The following is a description of a gene set: Conditional macrophage-specific PPARg knockout mice were generated on C57Bl/6 background by breeding PPARg fl/- (one allele is floxed, the other is null) and lysozyme Cre transgenic mice. PPARg and IL-4 signaling was analyzed on bone marrow-derived macrophages. Bone marrow of 3 mice per group was isolated and differentiated to macrophages with M-CSF (20 ng/ml). 20 ng/ml IL-4 was used to induce alternative macrophage activation and 1 uM Rosiglitazone (RSG) was used to activate PPARg. From each mouse 4 samples were generated: 1. M-CSF, 2. M-CSF+RSG, 3. IL-4 and 4. IL-4+RSG. All compounds were added throughout the whole differentiation process, and fresh media was added every other day. Control cells were treated with vehicle (DMSO:ethanol). After 10 days, RNA was isolated and gene expression profiles were analyzed using Mouse Genome 430 2.0 microarrays from Affymetrix. Human Gene Set: GSE25123_WT_VS_PPARG_KO_MACROPHAGE_IL4_STIM_DN from publication Szanto A, Balint BL, Nagy ZS, Barta E, Dezso B, Pap A, Szeles L, Poliska S, Oros M, Evans RM, Barak Y, Schwabe J, Nagy L (PMID 21093321) Genes down-regulated in bone marrow-derived macrophages treated with IL4: wildtype versus PPARG knockout. species: Homo sapiens, and this is the list of marker genes: KCNK6, CASS4, CYFIP1, CERS2, IL9R, EBI3, ICAM1, OSBPL3, ITGB8, MKI67, S100A4, FBXO4, PLSCR1, F13A1, POGLUT3, WLS, TNFRSF9, TMEM87A, CXXC5, MMD, ACTG2, IL18RAP, GCNT1, KRT5, CEMIP2, PDCD1, KLRG1, ITIH5, SLC15A3, EPDR1, DCXR, FUCA2, CD38, TTC39B, TSC22D1, GOLM1, SNX9, NXPE4, CD80, RAB8B, GPM6B, FOXP3, DRAM1, PTGER2, IL1R2, AHR, TRPM6, EHD4, TMEM62, LCLAT1, TTC39C, ZC3H12C, GSAP, DHRS3, EXPH5, MID2, AKR1C3, SKAP2, STX11, RNF128, NEB, NR4A2, S100A6, HAO1, KLF4, BTLA, FAM111A, S100A11 (NCBI Gene Id 6282), ITGAV, VMP1, ITPRIPL2, TXNDC5, CC2D2A, RAPH1, SEMA6D, VDR, ATP2B4, ENO3, NDFIP1, CCR2, VPS54, ABHD4, SLAMF1, TSPAN17 (tetraspanin 17), ANXA4, TMBIM1, TOP2A, LITAF, HIVEP3, CCR6, NCF4, ZC3H12D, FAM89A, BTBD3, PRELID2 (NCBI Gene Id 153768), S100A10, SHE, ITGAE, HPSE, ATP6V0D2, IRAK1BP1, NFKBIE, NFATC1, ACOT11, MAP3K8, BMPR2, KIF5C, HOPX, GJB2, SDCBP2, HMGB3, RASGEF1A, PRDM1, SOWAHC, LAMP2, HHEX, CRYBG3, ALCAM, WASHC5, LGALS7, FCRL1, SLC9B2, LGALS1, GPR15, CLDN12, EGR2, CTLA4, NSD2, RILPL2, SNX33, ZAN, GPAT3, PHLDA1, HNRNPLL, CASP3, BUB1, SRGN, PLEKHB2, HSD3B7, CLDND1, PLPP1, MED7, ERBB3, CAMK2D, CEP162, ENDOD1, EEA1, ARL6, DNAJC1, MAF, NRP1, BPIFC (NCBI Gene Id 254240), IKZF3, SCIN, VCL, ATP10D, ACADL, RAP1GAP2, TNFRSF4, TNFRSF1B, GABARAPL1, LRRN3, GYG1, RUNX2, SLC22A15 (NCBI Gene Id 55356), SEC11C, ANXA2, HSPA4L, TJP2, SYNPO, RAD51B, GABRA5, SAMSN1, IL21, SMAP1, TMEM65, SGO2, CCRL2, BCL2A1, PPFIBP1, HSPA13, CHST11, MRGPRE, POLA1, STAP1, PTPN3, CAPN2, SRGAP3, NSMAF, KRT6A, GZMB, ATCAY, IL1RL1, PEX11A, FHL2, LXN, KIFAP3, RIN2, ADAM8, ZDHHC2